The following is a description of a gene set: studied in species Mus musculus Reactome Pathway: CREB1 phosphorylation through the activation of Adenylate Cyclase electronically inferred by orthology from the curated human pathway This event has been computationally inferred from an event that has been demonstrated in another species.<p>The inference is based on the homology mapping from PANTHER. Briefly, reactions for which all involved PhysicalEntities (in input, output and catalyst) have a mapped orthologue/paralogue (for complexes at least 75% of components must have a mapping) are inferred to the other species. part of: Post NMDA receptor activation events, and this is the list of marker genes: Prkacb, Prkar2b, Prkar1b, Prkaca